The following is a description of a gene set: species: Mus musculus Mouse Gene Set: SCHAEFFER_PROSTATE_DEVELOPMENT_AND_CANCER_BOX5_DN Cancer cells differentiate along specific lineages that largely determine their clinical and biologic behavior. Distinct cancer phenotypes from different cells and organs likely result from unique gene expression repertoires established in the embryo and maintained after malignant transformation. We used comprehensive gene expression analysis to examine this concept in the prostate, an organ with a tractable developmental program and a high propensity for cancer. We focused on gene expression in the murine prostate rudiment at three time points during the first 48 h of exposure to androgen, which initiates proliferation and invasion of prostate epithelial buds into surrounding urogenital sinus mesenchyme. Here, we show that androgen exposure regulates genes previously implicated in prostate carcinogenesis comprising pathways for the phosphatase and tensin homolog (PTEN), fibroblast growth factor (FGF)/mitogen-activated protein kinase (MAPK), and Wnt signaling along with cellular programs regulating such 'hallmarks' of cancer as angiogenesis, apoptosis, migration and proliferation. We found statistically significant evidence for novel androgen-induced gene regulation events that establish and/or maintain prostate cell fate. These include modulation of gene expression through microRNAs, expression of specific transcription factors, and regulation of their predicted targets. By querying public gene expression databases from other tissues, we found that rather than generally characterizing androgen exposure or epithelial budding, the early prostate development program more closely resembles the program for human prostate cancer. Most importantly, early androgen-regulated genes and functional themes associated with prostate development were highly enriched in contrasts between increasingly lethal forms of prostate cancer, confirming a 'reactivation' of embryonic pathways for proliferation and invasion in prostate cancer progression. Among the genes with the most significant links to the development and cancer, we highlight coordinate induction of the transcription factor Sox9 and suppression of the proapoptotic phospholipid-binding protein Annexin A1 that link early prostate development to early prostate carcinogenesis. These results credential early prostate development as a reliable and valid model system for the investigation of genes and pathways that drive prostate cancer. from publication Schaeffer EM, Marchionni L, Huang Z, Simons B, Blackman A, Yu W, Parmigiani G, Berman DM (PMID 18794802) Early prostate development genes (down-regulated at 12 hr dihydrotestosterone) which are also down-regulated in high grade prostatic intraepithelial neoplasia (PIN) vs invasive cancer., and this is the list of marker genes: Tle1, Sox9, Tspan8, Cast, Tubb4a, Med4, Tmem45a, Lgals3